Given this list of marker genes ERP29, ALDH1A1, PDIA3, AKR1A1, AKR7A3, IDH2, ADH4, ALDH9A1, P4HB, PDIA5, AKR7A2, ALDH3A1, ALDH7A1, IDH1, PDIA4, here is a description of the gene set: Oxidoreductases. Human Gene Set: MODULE_519 species: Homo sapiens